Given this list of marker genes SPARC, B3GALNT1, PRX, F3, RNF24, RTN1, SLC12A2, EMCN, VIPR1, S100A4, GNG11, TGFBR3, UBB, CA4, LGALS1, GPX3, CYP3A5, CD74, SLC14A1, SOSTDC1, SERPINE1, IL1RL1, B2M, PRKCE, CD83, IL32, S100A3, DHRS7, AQP1, EMP2 (NCBI Gene Id 2013), ADGRL2, TBX2, ICAM2, EDNRB, ITM2B, TUBA1A (tubulin alpha 1a), HPGD, GPX1, S100A6, INMT, EXPH5, HOPX, here is a description of the gene set: Human Gene Set: TRAVAGLINI_LUNG_CAPILLARY_AEROCYTE_CELL from publication Travaglini KJ, Nabhan AN, Penland L, Sinha R, Gillich A, Sit RV, Chang S, Conley SD, Mori Y, Seita J, Berry GJ, Shrager JB, Metzger RJ, Kuo CS, Neff N, Weissman IL, Quake SR, Krasnow MA (PMID 33208946) studied in species Homo sapiens